The following is a description of a gene set: Binding to the C-terminal domain (CTD) of the largest subunit of RNA polymerase II. The CTD is comprised of repeats of a heptapeptide with the consensus sequence YSPTSPS. The number of repeats varies with the species and a minimum number of repeats is required for RNAP II function. Human Gene Set: GOMF_RNA_POLYMERASE_II_C_TERMINAL_DOMAIN_BINDING species: Homo sapiens, and this is the list of marker genes: PCIF1, SCAF4, RPRD2, SCAF1, LEO1, BRD4, RPRD1B, SCAF8, HNRNPU, RPRD1A